Given this list of marker genes SDK2, SDK1 (sidekick cell adhesion molecule 1), here is a description of the gene set: Sidekick-1 (SDK1) and sidekick-2 (SDK2) are cell adhesion molecules of the immunoglobulin superfamily expressed by nonoverlapping subsets of retinal neurons. They have been shown to function as neuronal targeting molecules, guiding developing neurons to specific synapses.<br>SDKs are concentrated at synapses that connect SDK-expressing pre- and postsynaptic partners, suggesting that their homophilic adhesion properties promote formation or stabilization of synapses. <br><br>SDKs promotes lamina-specific synaptic connections in the retina and are specifically required for the formation of neuronal circuits that detect motion. studied in species Homo sapiens Reactome Pathway: SDK interactions part of: Cell-cell junction organization